Given this list of marker genes Reln, Gprc5b, Adam17, Ptpn1, Grem1, Unc119, Abi1, Agt, Abi2, Agrn, Abi3, Dvl2, Lilra5, Fbxw7, Nox4, Csf1r, Efna1, Neurl1a, Wnt3a, Dok7, Cass4, Srcin1, Il34, Nedd9, Egf, here is a description of the gene set: Mouse Gene Set: GOBP_POSITIVE_REGULATION_OF_PROTEIN_TYROSINE_KINASE_ACTIVITY Any process that increases the rate, frequency, or extent of protein tyrosine kinase activity. species: Mus musculus